Given this list of marker genes Mpeg1, Magi1, Smpd3, Nfic, Wipf3, Ankrd1, Hoxb1, Ddx19b, Yrdc, Dgkz, Ppp1cb, Xxylt1, Lrba, Vmn1r56, Sarm1, Ak8, Gnb5, Ccdc137, Clock, Cbfa2t3, Cep350, N4bp1, Icos, Efnb3, Tead1, Plppr2, Rspry1 (ring finger and SPRY domain containing 1), Rere, Syt1, Gli2, Mov10 (Mov10 RISC complex RNA helicase), Zdhhc14, Clasp2, Wwp1, Sirpa, Cct6a, Bdh1, Dcdc2a, Tmem129, Runx3, St6galnac6, Srf, Sdc3, Stam2, Col24a1, Kng2, Ccdc149, Tbc1d16, Myef2, Emx2, Tmem42, Ndst1, Opcml, Ranbp9, Mrps21, Kdm5a, Yju2b, Tut4, Pappa2, Sh3kbp1, Aak1, Sult1c2, Il36g, Efemp1, Slc1a1, Acvrl1, Nsdhl, Ttyh2, Prr12, Uap1, Adcy1, Tpcn1, Gpr37, Med26 (mediator complex subunit 26), Cplx2, here is a description of the gene set: studied in species Mus musculus Mouse Gene Set: MIR_664_5P from publication Chen Y, Wang X (PMID 31504780) Genes predicted to be targets of miRBase v22 microRNA mmu_miR_664_5p in miRDB v6.0 with MirTarget v4 prediction scores > 80 (high confidence targets).